Given this list of marker genes KLHL41, KBTBD13, AFG3L2 (AFG3 like matrix AAA peptidase subunit 2, NCBI Gene Id 573970), COQ8A, CHCHD10, MSTO1 (misato mitochondrial distribution and morphology regulator 1), COL6A1, CACNA1S, STAC3, KCNE3, MIPEP, GAA, SELENON, HMGCR (NCBI Gene Id 3156), PYGM, SUCLG1, COQ9, ACTA1, ABHD5, GYG1 (NCBI Gene Id 2992), PHKA1, MYPN, MT-TE (mitochondrially encoded tRNA-Glu (GAA/G)), ENO3 (enolase 3), PHKG2, TRMU, TPM2, PHKG1, PNPLA2, TTN, TPM3, MT-TN, SDHA, PHKA2, SLC22A5, PHKB, SCN4A, ISCU, NDUFA4, COX6A2, COQ2, GYS1, KCNJ18, COQ4, PFKM, MYH7, COL6A2, COL12A1, NEB, SURF1, GABRA3, COL6A3, NDUFS4, CPT2, PDSS2, here is a description of the gene set: Human Gene Set: HP_ABNORMAL_MUSCLE_TISSUE_METABOLITE_CONCENTRATION Abnormal muscle tissue metabolite concentration species: Homo sapiens